The following is a description of a gene set: species: Homo sapiens Murine Cytomegalovirus (MCMV) infection leads to early activation of various immune cells, including B and T lymphocytes, before the actual initiation of antigen-specific adaptive immunity. This activation is partly driven by innate cytokines, including type I interferon (IFN), which are induced early after infection. The objective of this study was to address the role of type I IFN in shaping early/innate B and T cell responses to a primary acute viral infection. In order to decipher the specific impact of IFN-I on cell subsets, we performed a genome-wide expression analysis on WT splenic B and CD8 T lymphocytes isolated from C57BL/6 mixed bone marrow chimera mice. This study complements series GSE39555, which focused on early responses of NK cells and of the two subsets of conventional dendritic cells. Human Gene Set: GSE45365_HEALTHY_VS_MCMV_INFECTION_CD8_TCELL_IFNAR_KO_DN Genes down-regulated during primary acute viral infection in dendritic cells with IFNAR1 knockout: CD8A versus ITGAM+., and this is the list of marker genes: GLRA3 (NCBI Gene Id 8001), EP400 (E1A binding protein p400), BANF2, RASGEF1B, STPG1, CA5A, SPAG6, EN1, PHGDH, PRSS33, CLCA4, MIR3150BHG, CIB2, MIR3142HG, OXSR1, SAMD3, PTGDR, BMP5, TPPP2, ASGR2, TRIOBP, NOVA1, SSC5D, MCPH1-DT, OPN4, CRTC3, GNRHR, ADCY2, ACBD6, FAM117B, SIN3A, IL2RB (NCBI Gene Id 3602), SLCO6A1, RASGRF2, NEDD9, DOCK2, PYCR2, ARL4C, OR1Q1, OSTM1-AS1, CPAMD8, CASP4LP, LRG1, ADAM33, ETF1, BLNK, TRIM42, DESI1, SYT12, IL12A, ZFAT, KRT76, KIF21B, TMPRSS12, NOXO1, OLFM1, APLF, ZNF710, CCDC115, PLD4, MCHR2, KLLN, SNORA71A, TUBAL3, VPS26B, PCARE, MAPRE1, PWRN1, TAFA5, SCN8A, KRBOX1, CHMP2B, DEUP1, ENSG00000290598, BSN, ACAP1, KDF1, PITHD1, PRKAG3, TMEM232, SPATA31D1, TLX2, CHRM5, TTC5, FAAP100, TSPAN18, DMRT2, PCAT4, LAPTM5, CFAP47, CLCF1 (cardiotrophin like cytokine factor 1), SPATA33, PPARD (NCBI Gene Id 5467), IMPG1, TARP, HECA, CT83, FOSB, NEXMIF, ATPAF2, ATF6B, CA10 (carbonic anhydrase 10), WNT11, SLAMF8, TINAGL1, OR1F2P, TXLNGY, PIP, TLL1, PDE7B-AS1, SPRR2C, GAR1, LINC00113, HNRNPAB, CSGALNACT1, SLC15A1, DUSP13B, TREML3P, RIMKLA, SFMBT1, CLDN14, MAPT, TGM3, USP29, CCND1, WDR1, CTSF, HECW1, KLRF1, BIN3, PLPPR4, ZNF217, AP5S1, FRMPD1, CD72, SERPINA3, LYRM4-AS1, AGER, SLC51A, ZNF576, MCF2L2, EPHX2, MTMR4, CNTLN, OR1J2, AP3S2, NAV2, ANKRD54, PLCH1, COL11A2, LINC00626, SND1-IT1, MYH1, FOXJ3 (forkhead box J3), ARHGEF5, HBS1L, IGKV4-1, SH2D4B, RARA, UNC119B, VSIR, RGS16, FAM167A, CX3CR1, RBMY2FP, DDX54, BTN1A1, BEGAIN, CDH12, CHMP4B, NEB, CNTFR-AS1 (NCBI Gene Id 415056), PCYT1A, RARRES2, TNFAIP1, MRC1, ZNF717, H1-1, SEPTIN11, IL11, HNRNPDL, MOGAT1, ZBTB2, RHD, LCK, GNG8 (G protein subunit gamma 8), NUDT3, VWA1, IL22RA1, LINC01088, EXOC2, INO80D, ANKS3, LINC00663